The following is a description of a gene set: Mouse Gene Set: GOBP_CRANIOFACIAL_SUTURE_MORPHOGENESIS The process in which any suture between cranial and/or facial bones is generated and organized. species: Mus musculus, and this is the list of marker genes: Megf8, Frem1, Mmp16, Insig1, Fgfr2, Rab23, Bmp4, Mmp14, Twist1, Msx2, Tifab, Neurog1, Tmem107, Foxn3, Tgfb1, Gli3, Insig2, Fgf4